Given this list of marker genes GNAS, CREB1, NR3C1, PRKACB, MYL3, ADCY6, ADCY3, ADRB2, ADCY4, PRKAR1B, ADCY7, PLCB4, ADCY5, MYL4, PRKAR2A, ADCY2, ADCY8, MYL2 (myosin light chain 2), PLCB2 (phospholipase C beta 2), PLCB3, ADCY1, PRKACA, ADCY9, PLCB1, PRKAR1A, MYL1, here is a description of the gene set: studied in species Homo sapiens Human Gene Set: WP_ALBUTEROL_AND_BUDESONIDE_THERAPY_FOR_ASTHMA Albuterol and budesonide therapy for asthma